Given this list of marker genes NELL2, CPNE3, AIDA, PLA2G4A, UBXN4, TMEM47, DEFB1, ARL6IP5, TRAM1, CD164, SOX9, TOB1, ANXA3, CCT2, DMD, FGF14 (NCBI Gene Id 317685), CXCL8, SLC39A8, DUSP6, CXCL2, TPD52, ATP6AP2, FXR1, C6, CD55, PPBP (NCBI Gene Id 90374), FCGR3A, ACTR2, RGS1, SLC4A4, TMED2, FOS, SERPINA1, YWHAE, TWF1, UGCG, DNAJC12, RAB1A, UBE2J1, here is a description of the gene set: from publication Spira A, Beane JE, Shah V, Steiling K, Liu G, Schembri F, Gilman S, Dumas YM, Calner P, Sebastiani P, Sridhar S, Beamis J, Lamb C, Anderson T, Gerry N, Keane J, Lenburg ME, Brody JS (PMID 17334370) studied in species Homo sapiens Lung cancer is the leading cause of death from cancer in the US and the world. The high mortality rate (80-85% within 5 years) results, in part, from a lack of effective tools to diagnose the disease at an early stage. Given that cigarette smoke creates a field of injury throughout the airway, we sought to determine if gene expression in histologically normal large-airway epithelial cells obtained at bronchoscopy from smokers with suspicion of lung cancer could be used as a lung cancer biomarker. Using a training set (n = 77) and gene-expression profiles from Affymetrix HG-U133A microarrays, we identified an 80-gene biomarker that distinguishes smokers with and without lung cancer. We tested the biomarker on an independent test set (n = 52), with an accuracy of 83% (80% sensitive, 84% specific), and on an additional validation set independently obtained from five medical centers (n = 35). Our biomarker had approximately 90% sensitivity for stage 1 cancer across all subjects. Combining cytopathology of lower airway cells obtained at bronchoscopy with the biomarker yielded 95% sensitivity and a 95% negative predictive value. These findings indicate that gene expression in cytologically normal large-airway epithelial cells can serve as a lung cancer biomarker, potentially owing to a cancer-specific airway-wide response to cigarette smoke. Up-regulated genes that distinguished smokers with and without lung cancer. Human Gene Set: SPIRA_SMOKERS_LUNG_CANCER_UP